Given this list of marker genes SLC25A6, MCU, VDAC3, GRIN2A, CASP3, SLC25A4, SLC25A31, GRIN2C, GRIN1, SLC25A5, APAF1 (apoptotic peptidase activating factor 1), CYCS, PRNP, GRIN2D, GRIN2B, VDAC2, CASP9, VDAC1, here is a description of the gene set: Scrapie conformation PrPSc to transport of calcium. Pathway ID: N01200. Pathway type: Variant. Pathway class: nt06465 Prion disease. Human Gene Set: KEGG_MEDICUS_VARIANT_SCRAPIE_CONFORMATION_PRPSC_TO_TRANSPORT_OF_CALCIUM Pathway Definition from KEGG: PRNP* -> NMDAR -> Ca2+ -- MCU -> Ca2+(mito) -- MPTP -> CYCS == APAF1 -> CASP9 -> CASP3 studied in species Homo sapiens